The following is a description of a gene set: species: Mus musculus Genes predicted to be targets of miRBase v22 microRNA mmu_miR_539_5p in miRDB v6.0 with MirTarget v4 prediction scores > 80 (high confidence targets). from publication Chen Y, Wang X (PMID 31504780) Mouse Gene Set: MIR_539_5P, and this is the list of marker genes: Serpinb8, Rad54l2, Usp31, Cntn3, Ackr3, Caap1, Vmn1r171, Ssb, Alpl, Gm14632, Zfp65, Cct2, Krt34, Phtf2, Atl2, Gabrb2, B3gnt7, Tnrc6b, Sec16b, Gm14525, Saal1, Fbxo30, Sfxn1, Leprotl1, Mcm4, Pias2, Marveld2, Fbxl7, Ajuba, Zfpm2, Gpr141b, Vmn1r45, Ocm, Col25a1, Slc39a1, Atp7a, Dlgap1, Ap3s1, Map3k2, Ssbp2, Ide, Ccdc117, Drd1, Krt10, Bpnt2, Dscaml1, Macrod2, Camsap1 (calmodulin regulated spectrin-associated protein 1), Gm4297, Zfp574 (zinc finger protein 574), Ogn, Rasgrf2, Nell2, Lin7c (NCBI Gene Id 99335), Galntl6, Arl16, Phf3, Hnrnpu, Gm10230 (predicted gene 10230), Rtn3, Ube2k, Abca5, Arpp19 (cAMP-regulated phosphoprotein 19), Znrf3, Nbeal1, Gm5169, Clec4b2, Kcnmb2, Reps2, Creg1, Zbtb43 (NCBI Gene Id 71834), Zfp148, Sf3b1, Frmd7, Elavl1, Tmem161a, Bbip1, Kat7 (K(lysine) acetyltransferase 7), Nktr, Pcnx1, D130043K22Rik, Chic1, Zbtb41, Setbp1 (NCBI Gene Id 93678), Gm10147, Tbk1, Sestd1, Mycl, Sema3d, Gm10058, Sgo2a, Krtap31-3, Pik3r1, Pja2, Ppic, Pla2r1, Map2, Gm10488, Gm6121, Hus1, Pign, Cyp4b1, Adgre4, Tra2b, Gm10487, Mysm1, Dixdc1, Arl8b, Fsd1l, Or2t48, Clasp2, Camsap2, Tcea1, Spib, Lurap1l, Plch1, Dcx, Gm5934, Ubqln2, Raph1, Wapl, Svil, Mark2, Zfp458, Mospd2, Slx, Iws1, Suclg2, Hycc2, Mphosph9, Or2v1, Aak1, Ftsj1, Nup62, AI593442, Aldh6a1, Enc1, Strbp, Pakap, Apol7c, Golga5, C1qtnf2, A130010J15Rik, Kcng3, Tent4b, Rp2, Aass, Gm14819, Hif3a (NCBI Gene Id 53417), Atp6v1g1, Apol7a, Rnf20, Epha7, Tanc2, Vwc2l, Gbp5, Clrn1, Rspo2, Tpp1, Upk1b, Ankfn1, Gm4836 (NCBI Gene Id 22526), Nub1, Cd44, Zdhhc20, Pfdn2, Ahrr, Map3k8, Rpusd2, Hnrnpk, Megf11, Rngtt, Atp6v1a, Postn, Gm2030, Gm10096, Wdr1, Rapgef6, Wdr44, Manea, Vxn, Gpr155, Scmh1, Sbspon (somatomedin B and thrombospondin, type 1 domain containing), Gm2012, Pogk, Pals2, Zfp738, Gm10486, Exosc7, Ppp1r3a, Pcdhb18, Dmac2l, Zkscan1, Trmt11, Grk5, Dst, Nr4a2, Arsj, Ids, Wiz, Kcnk1, Spag9, Dsc2, Homer1, Samsn1 (SAM domain, SH3 domain and nuclear localization signals, 1), Elk1, 1110004F10Rik (RIKEN cDNA 1110004F10 gene), Dnajc3, Fam135a, Pno1, Pcbp2, Nfia, Ptger3, Cxcl14, Ncapd3, Appl1, Ark2c, Ephb1, Rock1, Prex2, Rab38, Mier1, Thoc2, Ttc14, Zfhx4, Dnal1, Lhx9, Rpap2, Basp1, Dnajc21, Frs2, Kcnj14, Sec24a, Defb1, Papola, Rbm27, Zfx (zinc finger protein X-linked), Isl1, Pon2, Sphkap, Zkscan8, Pi15, Pak3, Slc25a36, Ankrd55, Zbtb14, Il1rl1, Tpgs2, Rere, Wrn, Nudt12, Gas2, Csnk2a1, Mal2, Gabpb1, Lman1, Runx2, Asah2, Slf2, Man1a, Dlx2, Gucy1a2, Cript, Fbxo4, Clic5, Pde3b, Rfesd, Fnip1, Kcnd2